The following is a description of a gene set: part of: Glycogen storage diseases Reactome Pathway: Glycogen storage disease type Ib (SLC37A4) studied in species Homo sapiens The SLC37A4 transport protein in the endoplasmic reticulum membrane normally mediates the exchange of cytosolic glucose-6-phosphate and orthophosphate from the endoplasmic reticulum lumen. Defects in this transporter are associated with glycogen storage disease type Ib., and this is the list of marker genes: SLC37A4